The following is a description of a gene set: studied in species Homo sapiens Human Gene Set: GOBP_BODY_FLUID_SECRETION The controlled release of a fluid by a cell or tissue in an animal., and this is the list of marker genes: MED1, CELSR2, CEL, ABCB1, NEGR1, AQP5, VAMP2, CDO1, ALOX12B, PRL, NKX2-3, SLC22A2, STATH, EDN1, PRLR, CAV1, SCNN1B, NEURL1, NCOR2, AQP1, DDR1, SCT, SLC4A9, GHRHR, NPPB, KCNN4 (NCBI Gene Id 3783), ANO1, VIP, MT-CO2, ADORA1, MTCO2P12, CHRM3, VDR, SLC6A3 (solute carrier family 6 member 3), MTX1, GUCA2B, GUCA1B, DCANP1, STK39, STAT5A, NR1H2, TRAF3IP2 (NCBI Gene Id 25997), FOSL2, NEUROG1, CREB1, CYBA, XBP1, GPAT4, SLC29A1 (NCBI Gene Id 220811), ZBTB7B, ERBB4, NR1H3, STAT5B, TP73 (tumor protein p73), OAS2, OPRK1, WNK1 (NCBI Gene Id 9872), NPR1, NLRP6, NME1 (NME/NM23 nucleoside diphosphate kinase 1), USF2, VAMP8, ATG5, SOCS2, CSN3, CSN2, HIF1A, VAMP3, MUC2, FOXB1, PRKCE, PRICKLE1, HTR4, VEGFA, WNK4, SLC4A5, COPA (COPI coat complex subunit alpha), NCOA1, OXTR, UPRT, PPP3CA, LACRT, ATP7B, CHRM1, WNK3, TIFAB, FGF10, AGR2 (NCBI Gene Id 10551), HK2, CAD, APLN, P2RY2, ADA, CCND1, XDH